Given this list of marker genes BCR, ZIC2, NCR3LG1, AP1G1, DENND1B (DENN domain containing 1B), RNF170, APOBEC3F, UTRN, ZNF704, TCERG1 (NCBI Gene Id 10915), FAM217B, GON7, SIDT1, PAK5, BCL2, CPEB4, HIP1, LSMEM1, NAV1, MMP2 (NCBI Gene Id 4313), BCAR3, BRWD1 (NCBI Gene Id 54146), SLC26A3, SULT1C2, DHX40, MRPL11, TRIR, AAK1, NIPBL, RIMS3, RBIS, CNNM1, PKIA, LINC03042, TMEM63C, ZFP2, TMEM95, RBBP8, KIFC3, BCL6 (BCL6 transcription repressor), GALNT11, CLCN5, CCN4, RFX7, FOXJ3, ABCA4, USP46, GABRA1, ZNHIT6, BPIFA2 (BPI fold containing family A member 2), VWC2, EEF1A1, SH3TC2, ACAD9, DDX42, TXLNB, NR2F1, PDE3A, EXOC5, LINC01517, RPS6KC1, AMACR, BCOR, TNS1, CNTLN, STXBP5, C6orf141, AIF1L, ZNF585B, TCF7L2, EIF4G3, RNF213, ADAMTS15, TEDDM1, RAB2A, PARD3B, VDR, FIGN, HSD17B7, DIP2C, GFRA1, SLC4A8, PLEKHG7, DUSP18, CPSF6, VPS13D, ANKRD13C, ID2, TFAP2C, ESYT2, CHST3, CKAP2L, SESN3, RAB6B, NALF2, CHM, CSNK1A1L, SMAD2, LILRB5, SLC43A1, SV2B, SPRY4, FAR1, SCML4, SH3BGRL2, OTULINL, RASSF5, SMG7, BPIFA3, APOB, SYAP1, TBX18, CREBRF, GALNT15, ABCC12, FLI1, ZSWIM6, TBC1D20, G3BP2, CRELD2, TLCD2, ZBTB16, WDR20, ERG, SHROOM4, SPAG9, HMG20A, RGS1, CXCR1, MLEC, KLHL20, TMEM248, WDR82, TRAPPC12, here is a description of the gene set: Human Gene Set: MIR1237_3P Genes predicted to be targets of miRBase v22 microRNA hsa-miR-1237-3p in miRDB v6.0 with MirTarget v4 prediction scores > 80 (high confidence targets). species: Homo sapiens from publication Chen Y, Wang X (PMID 31504780)